The following is a description of a gene set: studied in species Homo sapiens Human Gene Set: GSE29618_PRE_VS_DAY7_POST_TIV_FLU_VACCINE_MDC_DN Systems vaccinology has emerged as an interdisciplinary field that combines systems wide measurements and network and predictive modeling applied to vaccinology. Here we used the systems vaccinology approach to study the molecular mechanisms underlying th from publication Nakaya HI, Wrammert J, Lee EK, Racioppi L, Marie-Kunze S, Haining WN, Means AR, Kasturi SP, Khan N, Li GM, McCausland M, Kanchan V, Kokko KE, Li S, Elbein R, Mehta AK, Aderem A, Subbarao K, Ahmed R, Pulendran B (PMID 21743478) Genes down-regulated in comparison of myeloid dendritic cells (mDC) from TIV influenza vaccinee pre-vaccination versus those at day 7 post-vaccination., and this is the list of marker genes: GLG1, HNF4G, PKP4, CHRNA5, MAN2B2, NUP42, SEPTIN11 (septin 11), MAP6D1, PAX7, PTPA, BIRC7, RGS10, RRP8, SUN1, DET1, RPL27, SRSF7, PPBP, TRIM15, MYH7, ZBTB20, SPPL2B (NCBI Gene Id 63937), BEST1, IQSEC1, FAM13B, TUBB4B, ARFRP1, CTPS2, CELA3A, KCNC4, LARS2, MTFR1, DCAF1, FBXO42, ECI1, RXRB, IL1R1 (interleukin 1 receptor type 1), RPL24, CDH11, SNCG, FAM216A (NCBI Gene Id 29902), MNAT1, POLR2G, CNNM1, SLC39A1, BCKDK (NCBI Gene Id 94996), SLC17A9, POLG, MAP3K14, LYRM9, TMEM212, IGFBP7, SP4, MAT1A, PRPS1L1, IGFLR1, CPSF6, ALPG, HYAL4, TXNDC9, SKIC3, NRDC, XRCC4, RPL7, C10orf88, RAF1, ATG9A, STATH, NIPSNAP3B, ASXL2, DIPK1A, DLGAP2, SULT1A2, SPIN2A, CCDC93, CHTOP, RRN3P1, INPP5J, MAP2K3, EFS, FTCD (formimidoyltransferase cyclodeaminase), ASPA, ATP5F1E, C1D, SEPTIN2, RABAC1, LANCL1, PKD2, FNBP1L, CTF1 (cardiotrophin 1), SNX11 (sorting nexin 11), LYL1, SDCBP, SCRIB, KRT1, MTG1, TUBB3, RETSAT, RAD51D, ZNF446, KDELR1, GTF2E2, PRKCI, IFT74, VTCN1, TSC1, ZW10, EPS8, SULT1A1, ZNF225, IL27RA, SMG9, NES, ST7, SLC30A1, GRK2, CAAP1, GOLT1B, ATP8B4, VPS37C, KRT23, SGSM2, MECP2, GNAL, CA2, AHR (aryl hydrocarbon receptor), SNHG3, MPDU1, CYP3A43, WDHD1, SLC20A2, DGKA, TRPC2, TACR3 (tachykinin receptor 3), CCDC51, GSK3B (NCBI Gene Id 2932), ICAM4, AMD1, HPGDS, TCF20, PMS1, ZNF557, ALDH3A1, DCAKD, RHCE, PROS1, IER5, DEPDC5, ARID5A, ADGRG3 (NCBI Gene Id 58870), ZNF613, TTLL7, TARBP1, CKLF, SGCE, RASSF1, AKT2, FAM184A, CDK6, USP36, CEP68, ST8SIA4, SAP30, WDR45, PLCG2, CRIP2, PDCD1LG2, CRIP1, PLA2G4C (phospholipase A2 group IVC), CHRNE, PODNL1, ALS2CL, ATP9B, ADAP1, NFE2L3, HCFC1R1, EIF2AK2, ARRB1, CYB5R3, FKBP3, LRP1, CFLAR, CES3, MYH1, RPA2, SH3GL1 (SH3 domain containing GRB2 like 1, endophilin A2), RETREG2, RTCA, NUMA1, SEC24A, SLC33A1, CD8A, SLC4A3, SLC4A5, ZNF250, COL1A2, ASB6, SYMPK